Given this list of marker genes TMEM43, RSPO1, BCKDHB, DPT, HEPH, GYG1, SOWAHC, GPD2, DERL1, UGT1A10, PGM1, ACAA2, GPX3, PDE8A, CHPT1, CCL11, TSC22D1 (TSC22 domain family member 1), CAVIN2, NRP1, PENK, ATP1B3, ADIPOR2, COL6A3, LUM, HADH, APLP2, HTRA1, MARCKS, PHLDB1, CHCHD10, GPAM, SRPX, ACAA1, KLF4, PTGES, ALDH1A1, PHYH, CPT2, ACTA2, here is a description of the gene set: from publication Landis MD, Seachrist DD, Montañez-Wiscovich ME, Danielpour D, Keri RA (PMID 15897883) Upregulation of HER2/ErbB2/Neu occurs in 15-30% of human breast cancers and correlates with poor prognosis. Identification of ErbB2/Neu transcriptional targets should facilitate development of novel therapeutic approaches. Development of breast cancer is a multistep process; thus, to identify the transcriptomes associated with different stages of progression of tumorigenesis, we compared expression profiles of mammary tumors and preneoplastic mammary tissue from MMTV-Neu transgenic mice to expression profiles of wild-type mammary glands using Affymetrix microarrays. We identified 324 candidate genes that were unique to ErbB2/Neu-induced tumors relative to normal mammary gland tissue from wild-type controls. Expression of a subset of these genes (82) was also changed in the preneoplastic mammary glands compared to wild-type controls, indicating that they may play a pivotal role during early events of ErbB2/Neu-initiated mammary tumorigenesis. Further analysis of the microarray data revealed that expression of several known transforming growth factor (TGF)-beta target genes was altered, suggesting that the TGF-beta signaling cascade is downregulated in ErbB2/Neu-induced tumors. Western blot analysis for TGF-beta-Receptor-I/ALK5 and immunohistochemistry for TGF-beta-Receptor-I/ALK5 and phosphorylated/activated Smad2 confirmed that the Smad-dependent TGF-beta signaling cascade was inactive in these tumors. Although absent in most of the tumor, phosphorylated Smad2 was present in the periphery of tumors. Interestingly, presence of phosphorylated/activated Smad2 correlated with expression of Activin-Receptor-IB/ALK4, suggesting that although Smad-dependent TGF-beta signaling is absent in ErbB2/Neu-induced tumors, Activin signaling may be active at the leading edge of these tumors. Cumulatively, these data indicate that the TGF-beta pathway is intrinsically suppressed in ErbB2/Neu tumors via a mechanism involving loss of TGF-beta-Receptor-I/ALK5. Human Gene Set: LANDIS_ERBB2_BREAST_TUMORS_65_DN Down-regulated genes from the 65 most significantly changed (p<0.01) genes identified by two analytical methods in the mammary tumors induced by transgenic expression of ERBB2. studied in species Mus musculus